Given this list of marker genes Aars1, Nsun2, Mob3a, Sdhaf1, Igkc, Prdx1 (peroxiredoxin 1), St8sia6, Serpina3g, Srgn (NCBI Gene Id 19073), Vars1, Lsm12, Tuba1b, Nme1, Nolc1 (NCBI Gene Id 70769), Idi1, Tmed9, Cd52, Grap, Basp1, Psme2, Gsr, Zfp36l2, Icosl, Glipr1, H2-Q7 (histocompatibility 2, Q region locus 7), Cd82, Swap70, Gns, Pa2g4, Dad1, Mif4gd, Eif1, Napsa, Marchf5, Slfn2, Myo1g, Pfn1, Gpm6b, Lyst, Sowahc, Herpud1, Kdr, Gpx4, Tank, Cfp, H2-Eb1, Zfp263, Trim30a, Relb, Snx11, Fdps, Sting1, Marchf2, Camta2, Ap3d1, Alcam (NCBI Gene Id 11658), H2-K1, Znhit1, H2-Aa, Csf2rb2, Slc52a2, Itga4, Them6, Cd74, Rbm17, Nlrc5, Scarb2, Srm, Nedd4, H2-Ab1, Bcl3, Cfl1, Cd40, Sub1, Slc15a3, B4galt5, Plaur, Il4i1, Hmgcs1, Fcer1g, Birc3 (baculoviral IAP repeat-containing 3), Abca7, Shisa5, Ddr1, Sh3bp4, Icam1, Cd44, Nfkb1, M6pr (mannose-6-phosphate receptor, cation dependent), Grk3, Cyba, Ccnd2, Tmem168, H2aj, Tapbp, Hspa4, Pim1, Tpm4, Klk1b27, Tnpo3, Snrnp25, Ly6a, Erh, Lgals3bp, Bccip, Hck, Ptpn1, Lynx1, Zc3h12c, Mrps14, Dhx9, Ykt6, Atp2b4, Bcl11a, Cpne2, Mknk2, Kynu, Tubb4b, Nfkbia, Lcp1, Mrpl2, Mpeg1, Fkbp5 (NCBI Gene Id 52022), Hint1 (NCBI Gene Id 15254), Ctsh, Kin, Nploc4, Dennd4a, Itgb3, Calr, Ebi3, Iqsec1, Ly6d, Atp5mc1, Eif5a, Ciita, here is a description of the gene set: Cytokines mediate cell-cell communication in the immune system and represent important therapeutic targets. A myriad of studies have highlighted their central role in immune function, yet we lack a global view of the cellular responses of each immune cell type to each cytokine. To address this gap, the authors created the Immune Dictionary, a compendium of single-cell transcriptomic profiles of more than 17 immune cell types in response to each of 86 cytokines (>1,400 cytokine-cell type combinations) in mouse lymph nodes in vivo. A cytokine-centric view of the dictionary revealed that most cytokines induce highly cell-type-specific responses. For example, the inflammatory cytokine interleukin-1β induces distinct gene programmes in almost every cell type. A cell-type-centric view of the dictionary identified more than 66 cytokine-driven cellular polarization states across immune cell types, including previously uncharacterized states such as an interleukin-18-induced polyfunctional natural killer cell state. Genes positively differentially expressed in cell type: pDC (plasmacytoid dendritic cell) upon treatment with cytokine: TNF-α in mouse lymph nodes in vivo. species: Mus musculus from publication Cui A, Huang T, Li S, Ma A, Pérez JL, Sander C, Keskin DB, Wu CJ, Fraenkel E, Hacohen N (PMID 38057668) Mouse Gene Set: CUI_PDC_TNFA_RESPONSE_UP